Given this list of marker genes Ubb, Rps27a, Smurf1, Tgfb1, Pard3, here is a description of the gene set: species: Mus musculus part of: Signaling by TGF-beta Receptor Complex electronically inferred by orthology from the curated human pathway Reactome Pathway: TGF-beta receptor signaling in EMT (epithelial to mesenchymal transition) This event has been computationally inferred from an event that has been demonstrated in another species.<p>The inference is based on the homology mapping from PANTHER. Briefly, reactions for which all involved PhysicalEntities (in input, output and catalyst) have a mapped orthologue/paralogue (for complexes at least 75% of components must have a mapping) are inferred to the other species.